The following is a description of a gene set: species: Homo sapiens Electron-dense granule occurring in blood platelets that stores and secretes adenosine nucleotides and serotonin. They contain a highly condensed core consisting of serotonin, histamine, calcium, magnesium, ATP, ADP, pyrophosphate and membrane lysosomal proteins. Human Gene Set: GOCC_PLATELET_DENSE_GRANULE, and this is the list of marker genes: ECM1, SELP, RARRES2, CTSW, APOH, TIMP3, CDC37L1 (cell division cycle 37 like 1, HSP90 cochaperone), ITPR1, RAB27B, LAMP2, ITIH4, CLEC3B, FAM3C, LGALS3BP, SPP2, SELENOP, CD63, HPS4, ITIH3, ABCC4, SERPINA4